Given this list of marker genes IRX2, SENP3 (NCBI Gene Id 26168), PCDH9, FSTL3, DYNC1LI2, CRTC1, WIZ, BTN3A2, here is a description of the gene set: species: Homo sapiens from publication Chen Y, Wang X (PMID 31504780) Genes predicted to be targets of miRBase v22 microRNA hsa-miR-132-5p in miRDB v6.0 with MirTarget v4 prediction scores > 80 (high confidence targets). Human Gene Set: MIR132_5P